Given this list of marker genes FOXA1, FGF8, YAP1, RARB, SLC9A4, TP63, SOX9, XBP1, CLCN2, SPDEF, ASCL1, RARA, CAV1, FZD5, WDR77, ZNF800, GATA2, LHX3, NFIB, NOTCH1, NR5A2, BHLHA15, WNT4, PGR, BMP2, GPAT4, CTNNB1, NKX6-3, HIF1A, IL31RA (NCBI Gene Id 386652), FGFR2, FGF2, PROX1, INSM1, RARG, EXT1, here is a description of the gene set: The process in which a relatively unspecialized cell acquires specialized features of a glandular epithelial cell. A glandular epithelial cell is a columnar/cuboidal epithelial cell found in a two dimensional sheet with a free surface exposed to the lumen of a gland. studied in species Homo sapiens Human Gene Set: GOBP_GLANDULAR_EPITHELIAL_CELL_DIFFERENTIATION